The following is a description of a gene set: Human Gene Set: GOBP_NEGATIVE_REGULATION_OF_MITOCHONDRIAL_FUSION species: Homo sapiens Any process that decreases the frequency, rate or extent of merging of two or more mitochondria within a cell to form a single compartment., and this is the list of marker genes: ADCK1, PRKN, TFRC, BNIP3, HUWE1, VAT1, MUL1, OMA1